Given this list of marker genes Mmp9, Stk11, Esam, Il10, Aggf1 (NCBI Gene Id 66549), Espl1, Sell, Chd1l, Igf2bp2, Ifng, Trp53, Brca2, Spn, Mir301, Cd47, Tnfrsf1a, Cdkn1b, Cdkn2a, Trap1, Pten, Myc, Adam15, Bub1, here is a description of the gene set: Mouse Gene Set: MP_DECREASED_TUMOR_INCIDENCE from publication Motenko H, Neuhauser SB, O'Keefe M, Richardson JE (PMID 26092688) Mouse genes annotated to decreased tumor incidence (MP:0002052) retrieved from the Mouse Genome Informatics database via MouseMine studied in species Mus musculus